The following is a description of a gene set: species: Homo sapiens Acquired drug resistance is a major obstacle in cancer therapy. As for many other drugs, this is also the case for gemcitabine, a nucleoside analogue with activity against non-small cell lung cancer (NSCLC). Here, we evaluate the ability of bexarotene to modulate the acquisition and maintenance of gemcitabine resistance in Calu3 NSCLC models. In the prevention model, Calu3 cells treated repeatedly with gemcitabine alone gradually developed resistance. However, with inclusion of bexarotene, the cells remained chemosensitive. RNA analysis showed a strong increase of rrm1 (ribonucleotide reductase M1) expression in the resistant cells (Calu3-GemR), a gene known to be involved in gemcitabine resistance. In addition, the expression of genes surrounding the chromosomal location of rrm1 was increased, suggesting that resistance was due to gene amplification at the chr11 p15.5 locus. Analysis of genomic DNA confirmed that the rrm1 gene copy number was increased over 10-fold. Correspondingly, fluorescence in situ hybridization analysis of metaphase chromosomes showed an intrachromosomal amplification of the rrm1 locus. In the therapeutic model, bexarotene gradually resensitized Calu3-GemR cells to gemcitabine, reaching parental drug sensitivity after 10 treatment cycles. This was associated with a loss in rrm1 amplification. Corresponding with the in vitro data, xenograft tumors generated from the resistant cells did not respond to gemcitabine but were growth inhibited when bexarotene was added to the cytotoxic agent. The data indicate that bexarotene can resensitize gemcitabine-resistant tumor cells by reversing gene amplification. This suggests that bexarotene may have clinical utility in cancers where drug resistance by gene amplification is a major obstacle to successful therapy. Human Gene Set: TOOKER_GEMCITABINE_RESISTANCE_UP from publication Tooker P, Yen WC, Ng SC, Negro-Vilar A, Hermann TW (PMID 17483357) Up-regulated genes in Calu3 cells (non-small cell lung cancer, NSCLC) resistant to gemcitabine which became down-regulated in response to bexarotene., and this is the list of marker genes: TRIM68, ILK, ACVR1B, TOMM34, RPL15, RPL28, AIMP2, CD81, PON2, PEG10, TPP1, BLVRB, HBE1, WDR74, PALLD, AATF, TRIM21, EIF3F, RNH1, ARID5B, TRIM34, DHRS7, ACSL5, ERVMER34-1, RXYLT1, CCNB1IP1 (cyclin B1 interacting protein 1), TMED3, SAT1, IRF9, FGF9, ODC1, BLTP2, COX8A, ATXN7L3B, NUP98, ADIRF, PTDSS1, TRIM22, HBG1, CIAPIN1, PFDN5, ZFAND3, ASS1, TPI1, RRP8, TSSC4, FTH1, TCF7L2, ABHD14A, SLC25A6, ELOVL1, LGALS3, PDE4B, ISG15, HSPA4, SNRPB, GRHPR, IFI6, CPOX, MRPL17, XRCC5, ARFIP2, NAP1L4, ZNF292, ITPA, ATP5PO, SP110, CIRBP, ABCC2, TIMM10B, MEF2C, CAVIN3, DSC3, ANXA1, IFT52, SLC25A3, RRM1, BDH2, BAMBI, BMP4